Given this list of marker genes CCL5, FOXP3, TNF, IL10, IDO1, LTA, TNFAIP3, ADORA2B, CYP19A1, here is a description of the gene set: studied in species Homo sapiens Human Gene Set: GOBP_REGULATION_OF_CHRONIC_INFLAMMATORY_RESPONSE Any process that modulates the frequency, rate, or extent of a chronic inflammatory response.